The following is a description of a gene set: Human Gene Set: MIR4680_5P from publication Chen Y, Wang X (PMID 31504780) species: Homo sapiens Genes predicted to be targets of miRBase v22 microRNA hsa-miR-4680-5p in miRDB v6.0 with MirTarget v4 prediction scores > 80 (high confidence targets)., and this is the list of marker genes: CREB5, NIN, ANKRD13A, ZNF641, NOVA1, NR1D2, IER5, SLAMF7, RNF114, SMARCA2, TMSB4Y, ZNF814, GIPC2, ZNF492, PHTF1, ZNF776, CCDC88A, TRAPPC2, ZNF606, MAP1B, AXIN2, SESTD1, ATP5MF-PTCD1, DNAJC14, MAP7 (microtubule associated protein 7), ZNF586, CNKSR2, ARHGEF9, EDAR, MIER1, SAMD9, HAUS6, PTCD1, UBFD1 (ubiquitin family domain containing 1), MAGI3, LRATD2, ZNF195, SC5D, XPO5, PRCP, ZNF14, AGO3, PSMD12, KMT2A, ECPAS, CYRIA, CWC25, ZNF532, SMARCC2, ATP11C, WASHC4, PRKG1, GALNT16, NFIB, SCUBE2, ZNF655, NOG, PACSIN1, CTBP2, MSL1, DIXDC1, FYTTD1, VAPA (VAMP associated protein A), SALL1, GALK2, CIMIP2A, USP34, CBLB, UBA6, HYKK